Given this list of marker genes Xab2, Lsm4, Usp4, Tarbp2, Gemin4 (NCBI Gene Id 320517), Znhit6, Ago2, Strap, Gemin2, Abt1, U2af2, Srpk1, Scaf11, Eif3g, Prkdc, Fau, Celf5, Rpl13a, Yju2, Hsp90ab1, Pwp2, Nop53, Gemin6-ps, Rps6, Rbmx, Clp1, mt-Rnr1, Taf9, Nufip1, Trim21, Dnajc17, Tdrd6, Wdr77, Rrs1, Sf3a1, Hsp90aa1, Celf1, Eif3d, Naf1, Ddx20, Prpf8, Eif5, Prkra, Mdn1, Atr, Kif5b, Eif3f, Sf3b1, Eral1, Eif3c, Pih1d2, Ncbp1, Srsf1, Prpf3, Ddx28, Celf2, Nvl, Luc7l, Ddx46, Pih1d1 (PIH1 domain containing 1), Chaer1, Mrm2, Sf3a2, Dicer1, Gemin6, Rpl10l, Mrto4, Prpf4b, Xrcc5, Dyrk3, Dhx30, Srsf6, Mrps7, Rps15, Nol3, Ptbp2, Ago3, Gemin5, Rcc1l (reculator of chromosome condensation 1 like), Srpk2, Eif2s3y, Rpl5 (ribosomal protein L5), Shq1 (NCBI Gene Id 72171), Celf4, Eif2s3x, Dhx29, Fastkd2 (NCBI Gene Id 75619), Gemin8, Sart3, Rps19, Faf2, Denr, Srsf12, Luc7l2, Ruvbl2, Rpl24, Usp39, Rps25, Prpf18, Rpl11, Isy1, Rps27, Eif2s2, Eif3h, Rpsa, Snrpd2, Rps6-ps4, Ptges3-ps, Snrpc, Snu13, Eif3k, Srpk3, mt-Rnr2, Celf6, Snrpf, Rbm5, Clns1a, Crnkl1, Srsf10, Psip1, Tssc4, Prpf31, Khdc4, Celf3, Ptges3, Slu7, Prpf39, Eif3a (eukaryotic translation initiation factor 3, subunit A), Bop1 (block of proliferation 1), Eif3j2, Htatsf1, Snrpd1, Ago4, Rsrp1, Rps27l, Tfip11, Atm, Klc1, Eif6, Mbnl1, Rpf2 (NCBI Gene Id 67239), Gcfc2, Lsm2, Ythdc1, Snrpb, Smn1, Eif3b, Zfand1, Snrpg (small nuclear ribonucleoprotein polypeptide G), Eif3e, Sf3a3, Rpl38, Eif3m, Setx, Nop2, Eif3i, Prpf19, Luc7l3 (LUC7-like 3 (S. cerevisiae)), Eif4h, Ago1, Dhx9, Snrpd3, Puf60, Ckap5, Snrpe, Mcat, Dkc1, Znhit3, Vcp, Ddx39b, Mcts1, Aar2, Rps14, Mettl17, Eif4b, Ruvbl1, Rps28, Prpf6, Eif3j1, Coil, Mcts2, Brix1, Prmt7, Eif2d, Rrp7a, Snrpert, Adar (adenosine deaminase, RNA-specific), Nopchap1, Gemin7, Eif3l, Snrnp200, Sfswap, Ddx42, Prmt5, Zrsr2, Rps5, here is a description of the gene set: Any process in which macromolecules aggregate, disaggregate, or are modified, resulting in the formation, disassembly, or alteration of a ribonucleoprotein complex. Mouse Gene Set: GOBP_PROTEIN_RNA_COMPLEX_ORGANIZATION studied in species Mus musculus